Given this list of marker genes IL2RA, CA2, IDUA, CD40LG, IDS, PIK3R1, AKT2, here is a description of the gene set: Enlarged tonsils Increase in size of the tonsils, small collections of lymphoid tissue facing into the aerodigestive tract on either side of the back part of the throat. Human Gene Set: HP_ENLARGED_TONSILS species: Homo sapiens